Given this list of marker genes GRP, VAMP2, KCNE1, KCNQ1, LRRC26, KCNRG, ANK3, KCNAB1, LRRC38, LRRC55, KCNE2, GALR2, LRRC52, SUMO1, GAL, KCNE3, here is a description of the gene set: studied in species Homo sapiens Any process that modulates the frequency, rate or extent of potassium ion transmembrane transporter activity. Human Gene Set: GOBP_REGULATION_OF_POTASSIUM_ION_TRANSMEMBRANE_TRANSPORTER_ACTIVITY